Given this list of marker genes Atp5pf, Oxsm (NCBI Gene Id 97924), Mrpl12, Idh3a, Aco2, Shmt2, Pdk1, Ssbp1, Nadk2, Glud1 (NCBI Gene Id 14661), Fech, Ndufv3, Mdh2, mt-Atp6, Dbt, Mrps10, Hadh, Twnk, Ech1, Pccb, Spg7, Atp5f1b, Arg2, Ndufs3, Atp5pd, Cox5a (NCBI Gene Id 12858), Ndufa13, Iars2, Hsd17b10, Alas1, Tfam, Ndufs1, Suclg2 (succinate-Coenzyme A ligase, GDP-forming, beta subunit), Cox5b, Mrps2, App, Me2, Mrpl32, Hspa9, Pmpca, mt-Co1, Fh1 (fumarate hydratase 1), Idh2, Hmgcs2, Acot3, Prkaca (protein kinase, cAMP dependent, catalytic, alpha), Atp5po, Acat1, Acot1, Acot5, Aldh1b1, Pdha1, Clpp, Atp5mg, Bdh1, Ndufv1, Slc25a5, Ndufa2, Aldh18a1, Aldh2, Dld, Cs, Ogdh (oxoglutarate (alpha-ketoglutarate) dehydrogenase (lipoamide)), Htra2, Acad8, Atp5f1a, Eci1, Lonp1, Acot2, Uqcrc2, Uqcrq, Acadsb, Oxct1, Clpx, Afg3l2, Hspd1, Pdhb, Star, Smdt1 (single-pass membrane protein with aspartate rich tail 1), Ldhd, Atp5f1c, here is a description of the gene set: Mouse Gene Set: REACTOME_MITOCHONDRIAL_PROTEIN_DEGRADATION Mitochondrial protein degradation species: Mus musculus